Given this list of marker genes CCNB1IP1, CCNB2, CDC25C, CDK1, CDKN1A, CCNB1, here is a description of the gene set: Human Gene Set: ZERBINI_RESPONSE_TO_SULINDAC_DN Numerous studies show that nonsteroidal anti-inflammatory drugs (NSAIDs) are effective in chemoprevention or treatment of cancer. Nevertheless, the mechanisms underlying these antineoplastic effects remain poorly understood. Here, we report that induction of the cancer-specific proapoptotic cytokine melanoma differentiation associated gene-7/interleukin-24 (MDA-7/IL-24) by several NSAIDs is an essential step for induction of apoptosis and G(2)-M growth arrest in cancer cells in vitro and inhibition of tumor growth in vivo. We also show that MDA-7/IL-24-dependent up-regulation of growth arrest and DNA damage inducible 45 alpha (GADD45alpha) and GADD45gamma gene expression is sufficient for cancer cell apoptosis via c-Jun NH(2)-terminal kinase (JNK) activation and growth arrest induction through inhibition of Cdc2-cyclin B checkpoint kinase. Knockdown of GADD45alpha and GADD45gamma transcription by small interfering RNA abrogates apoptosis and growth arrest induction by the NSAID treatment, blocks JNK activation, and restores Cdc2-cyclin B kinase activity. Our results establish MDA-7/IL-24 and GADD45alpha and GADD45gamma as critical mediators of apoptosis and growth arrest in response to NSAIDs in cancer cells. Selected genes down-regulated in DU145 and PC-3 cells (prostate cancer) after treatment with the NSAID (non-steroid anti-inflammatory drug) sulindac. from publication Zerbini LF, Czibere A, Wang Y, Correa RG, Otu H, Joseph M, Takayasu Y, Silver M, Gu X, Ruchusatsawat K, Li L, Sarkar D, Zhou JR, Fisher PB, Libermann TA (PMID 17178890) studied in species Homo sapiens